The following is a description of a gene set: Apoptosis regulation by parathyroid hormone-related protein Human Gene Set: WP_APOPTOSIS_REGULATION_BY_PARATHYROID_HORMONERELATED_PROTEIN studied in species Homo sapiens, and this is the list of marker genes: BID, BCL2L14, AKT1 (AKT serine/threonine kinase 1), PIK3CG, AKT2, BCL2L15, BCL2L13, BCL2, BCL2L10, BCL2L2, ADAMTSL4-AS1, GSK3A, BCL2A1, BCL2L1, PTHLH, BAX, BAK1, MYC, BCL2L12, AKT3, ITGA6, MCL1, BOK, GSK3B, ITGB4